The following is a description of a gene set: studied in species Homo sapiens Longitudinal densities on radiographs located in a metaphysis (the narrow region of a long bone between the epiphysis and the diaphysis). Metaphyseal striations Human Gene Set: HP_METAPHYSEAL_STRIATIONS, and this is the list of marker genes: ANAPC1, KIF22, ADA, RECQL4, PISD, AMER1, RAB3GAP2, WDR26, NANS, RMRP, TONSL, PORCN, MTAP, POLE